The following is a description of a gene set: studied in species Mus musculus Peroxisome proliferator-activated receptor gamma (PPARgamma) activity is regulated through association with ligands that include the thiazolidinedione class of antidiabetic drugs, as well as derivatives of polyunsaturated fatty acids. Induction of PPARgamma target gene expression involves ligand-dependent reconfiguration of the ligand-binding domain (LBD), followed by recruitment of specific transcriptional coactivators. In this study, we have identified an amino acid (F372) within helix 7 of the LBD that is required for the response of PPARgamma to endogenous ligands. Additionally, the data show that this amino acid is also required for expression of a novel subset of adipocyte genes (group 2), including fibroblast growth factor 21 (FGF21), and that the FGF21 gene is a direct target of PPARgamma. Expression of the group genes is selectively repressed by the NAD-dependent deacetylase SIRT1 in mature 3T3-L1 adipocytes, since knockdown of SIRT1 through the constitutive expression of a corresponding RNA interference enhances their expression without affecting the expression of classic adipogenic genes, such as adiponectin and FABP4/aP2. It appears that many of the group genes repressed by SIRT1 in mature adipocytes correspond to the same set of genes that are selectively activated by treatment of fat cells with the PPARgamma ligand, troglitazone. These data support a role for helix 7 of the LBD of PPARgamma in regulating adipocyte function and suggest that inhibition of SIRT1 in adipocytes induces the same insulin-sensitizing action as PPARgamma ligands. Mouse Gene Set: WANG_CLASSIC_ADIPOGENIC_TARGETS_OF_PPARG from publication Wang H, Qiang L, Farmer SR (PMID 17954559) Classic adipogenic genes (group 1) that are induced by PPARG during adipogenesis in 3T3-L1 preadipocytes., and this is the list of marker genes: Aldh1a7, Hsd11b1, Nr1h3, Retn, Crat, Cidec, Dgat1, Cfd, Acsl1, Orm1, Ppargc1b, Mgst3, Fabp4, Aqp7, S100a1, Pex11a, Plin4, Lgals12, Cebpa, Pnpla2, Cd36, Fabp5, Mgst1, Slc25a10, Adhfe1, Glul, Ephx2